Given this list of marker genes Pxdn, Nid1, Shh, Slit2, Dag1, Ntn4, Thbs4, here is a description of the gene set: Mouse Gene Set: GOMF_LAMININ_1_BINDING Binding to laminin-1, a glycoprotein trimer with the subunit composition alpha1, beta1, gamma1. species: Mus musculus